Given this list of marker genes COL1A1, FAM20C, KL, IL1RN, TRPV6, GALNT3, FGFR2, SLCO2A1, here is a description of the gene set: studied in species Homo sapiens Abnormal periosteum morphology Human Gene Set: HP_ABNORMAL_PERIOSTEUM_MORPHOLOGY An anomalous structure of the periosteum, i.e., of the membrane that covers the outer surface of bones.